Given this list of marker genes LTBP3, TGFBR1, PTPN11, RARG, PTHLH, ADAMTS7, WNT9A, IHH, RFLNA, RFLNB (NCBI Gene Id 359845), EFEMP1, SNAI2, SOX9, GDF5, NR5A2, CCN4 (NCBI Gene Id 8840), GLI3, CTNNB1, NKX3-2, RARB, ADAMTS12, GREM1, CHADL, PTH, BMP4, here is a description of the gene set: Human Gene Set: GOBP_NEGATIVE_REGULATION_OF_CHONDROCYTE_DIFFERENTIATION species: Homo sapiens Any process that stops, prevents, or reduces the frequency, rate or extent of chondrocyte differentiation.